The following is a description of a gene set: Human Gene Set: GOBP_OVULATION_CYCLE_PROCESS studied in species Homo sapiens A process involved in the sexual cycle seen in females, often with physiologic changes in the endometrium that recur at regular intervals during the reproductive years., and this is the list of marker genes: CASP2, SGPL1, SLIT3, SCAPER, MSTN, TNFAIP6, FSHB, AFP, PLEKHA1, FOXO3 (NCBI Gene Id 2309), PTX3, ROBO2, GAS2, CASP3, ZNF830, SIRT1, PGR, NOTCH1, TGFB2, TGFB3, AMH, NPPC, PTPRN, STAT5B, NR5A2, MMP19, RETN, NPY5R, BMPR1B, ESR1, LEP, ADAMTS1, NPR2, NR5A1, FZD4, PDGFRA, SLIT2, NRIP1, NOS3, CGA, FSHR, INHBA, NOTCH4, GPR149, EREG, GDF9, STAT5A, LHCGR, ZP3, MMP2